The following is a description of a gene set: from publication Chen Y, Wang X (PMID 31504780) Genes predicted to be targets of miRBase v22 microRNA hsa-miR-6752-3p in miRDB v6.0 with MirTarget v4 prediction scores > 80 (high confidence targets). Human Gene Set: MIR6752_3P species: Homo sapiens, and this is the list of marker genes: PTBP2, ARHGEF19, KLF13, FAM163A, MYOG, MAPKBP1, LMX1B, NLGN2, TMEM104, WNT4, HCFC1, ANO1, PHF12, DERL2, TMEFF2, KLHL6, APLNR, ZNF324, HOMER2, SNX19, DNMT3B (DNA methyltransferase 3 beta), CTNND1, EFNB1 (NCBI Gene Id 1947), ICE2, FOXP4, MMP24, KNCN, RBFOX2, ST13, PPP1R18, POMT2, NXPH3, SCRN1, CPD, AGO1, SP1, NFASC, KDM7A, ST8SIA2, BRWD3, CD274, CASD1, ZFP41 (ZFP41 zinc finger protein), NHS, MVK, NRIP3, HIC2, SERPINF2, GRAP2 (GRB2 related adaptor protein 2), RIPOR1, MLEC, GUCY2D, GLCCI1, ATP6V0A1, DMRTC2, POU2F2, FOXO4, GRHL1, SCAMP2, HS1BP3, GPX3, P2RY2, DCAKD, KDM6B, ATRN, BTBD9, KCNAB2 (NCBI Gene Id 8514), LYNX1, STK40, RNF7, OTOA, CPLANE2, CTNNBIP1, KCNQ4, DNM1L, VASH1, ATXN1L, PHF2, FBRS, SEPSECS, GSG1L, SMAP2, EDEM1, PDGFB, KCNH3, TXNRD1, IP6K1, LIMS1, DLG4, SNX8, DTNA, CXCR5, NTRK3 (neurotrophic receptor tyrosine kinase 3), PRR12, ELOA, CASTOR2, PTAFR, CDS2, CRTC1, CALN1, FTSJ1, SNPH, SRFBP1 (NCBI Gene Id 153443), MICAL2, SUFU, TUB, PNISR, ENSA, AGAP1, EXOC7, ZBTB4, PPP2R5D, ETV6, GPR6, CADM4 (cell adhesion molecule 4), ADRB2, ELFN2, GPCPD1, TNFAIP2, GPR17, AQP1, NEURL1, XYLT2, ADAM15 (ADAM metallopeptidase domain 15), LINC02693, RAD23B, CNBD2, RNF40, MAP3K13, IQSEC3, JADE1, CLDN19, SLC6A17, IKZF4, TRPV5, FAM222A, TBC1D7, ARHGAP28, CCDC22, PTPRU, MINK1, EFR3B, PIP4P1, LTA